Given this list of marker genes YIF1B, ERGIC2, TMED7, LAMP5, ATP6AP1, AREG, ROBO1, RER1, CHP1, TMEM203, STX5, VMP1, CA4, SCYL1, NUCB1, GALNT1, RAB37, TMEM199, RAB6B, STK17B, COL7A1, BCAP31 (B cell receptor associated protein 31), SERPINH1, VPS13B, COPZ2, ZDHHC9, LMAN2L, NUCB2, PROM1, INPP5B, PLPP3, LMAN1, MGAT4D, CTSZ, CNIH2, CD55, TBC1D20, TAP2, MTMR6, HMGB1, COPG1, ATP2A1, TRIP11, MGAT4B, SURF4, TMED10, ANPEP, TMED3, CNIH4, PDIA6, TMED9, KDELR1, STX17, MCFD2 (NCBI Gene Id 90411), PIEZO1, MPPE1, MYO18A, SLC35C2, F5, RAB1B, SERPINA1, FOLR1, WHAMM, CTSC, GNPNAT1, NAT8, CD59, UGGT2, RGMB, HSPA5, COPG2, LMAN2 (lectin, mannose binding 2), LRPAP1, MGAT1, GOSR2, COPB1, DCSTAMP, SEC22B, ASPSCR1, GOLGA2, P4HB, UVRAG, NAT8B, TMED1, ZDHHC20, TMED4, STING1, TRAPPC2, ERGIC3, SEC23IP, PRRG4, DDHD2, ERP44, TMED2, CALR, YIPF7, TAP1, GORASP1, LMAN1L, FN1, GOLGB1, TMED6, VMA21, YKT6, YIF1A, IST1, PTPN2, MGAT4A, TGFA, PALS1, UGGT1, TM6SF2, GJB2, GRIA1, TRAPPC12, SMO, TRAPPC5, INS, CLN8, MAN1A1, RAB2A, TRAPPC2B, F8, MYDGF, CNIH1, TMED5, AZIN2, ERGIC1, FTCD, SPPL3, CCDC115, BET1, CNIH3, ECPAS, TAPBP (TAP binding protein), CSNK1D, GBF1, here is a description of the gene set: Human Gene Set: GOCC_ENDOPLASMIC_RETICULUM_GOLGI_INTERMEDIATE_COMPARTMENT A complex system of membrane-bounded compartments located between endoplasmic reticulum (ER) and the Golgi complex, with a distinctive membrane protein composition; involved in ER-to-Golgi and Golgi-to-ER transport. studied in species Homo sapiens